Given this list of marker genes Oxct1, Bnip3l, Grn (granulin), Sat1, Zeb2, Adcy7, Ucp2, Lpin1, Abca1, Hbp1, Neurl3, Ccl9, Junb, Aph1c, Apobec1, Adgre4, Lnpep, Prcp (NCBI Gene Id 72461), Igsf6, Fam111a, Il16, Il6ra, Kif21b, Egr1, Stap1, Map4k4, Lst1, Pdcd4 (programmed cell death 4), Crebrf, Cx3cr1, Arhgap9, Lmo4, Cxcr4, Rtn3, Fos, Csk, Plekhm3, Cd180, Kxd1, Hpse, Cerk, Mxd4, Nr4a2, Tsc22d4, Tsc22d3, Foxp1, Alox5ap, Rhob, Parp8, Setx, Txnip (NCBI Gene Id 99524), Il6st, Eif4b, Ctsd (NCBI Gene Id 13033), Ccpg1, Stom (stomatin), Tut4, Ptp4a3, Sgk1 (serum/glucocorticoid regulated kinase 1), Tmem50a, Adgre1, Dnajb14, Fuca1, Lars2 (NCBI Gene Id 245051), Mapk14, Tmcc1, Hspa1a, Smpdl3a, Uba52, Creg1 (cellular repressor of E1A-stimulated genes 1), Bmyc, Ifngr1, Ctsc, Jun, Cox7a2l, Bri3, Nek7, Pik3cg (NCBI Gene Id 76039), Smim14, B4galnt1, Ankrd44 (ankyrin repeat domain 44), Hebp1, Rsrp1, Cd300ld, Ralbp1, Inpp5d, Akap13, Paip2, Nr4a1, Cd300c2, Smc6, Stk38, Il10rb, Anp32a, Stk17b, Timp2 (NCBI Gene Id 52894), Clec2i, Eif3h, Pstpip1, Ctdsp2 (NCBI Gene Id 52468, CTD small phosphatase 2), Gdi2, Ogt, Zfp36l2, Susd3, Rgs10, Cdkn1b, Rgs1, Csnk1g3, Sirpa, Acp5, Ptgs2, Pid1, Klf2, Rab32, Saraf, Ppfia4, Ier2, Deptor, Rnf130, Nav1, Fth1, Plekha1, Cd4, Il13ra1, Slc15a4, Slc12a6, Ccrl2, Mef2c, Bri3bp, Erp29, Polr2e, Borcs6, Fes, Ccl6, H1f2, Il1b, Fam107b, Ramp1, Clec4a1, Gng2, Ptpn18, Ccr2, Leprot, Eef2, Clk1, Pmaip1, Btg2, Ctsh, Haus8, Tnfaip8, Tm6sf1, Clec4a2, Dpy19l1, Ehd4, Smim5, Man2b1, Ttc3, Sox4, Kdm7a, Dusp1, Plxnd1, Cyb5a, Klrd1, Ncf2, Itm2b, Ighm, Arhgap45, Irag2, Rcsd1, Atp2b1, Mbnl2, Npc2, Nfkbiz, Ypel3, Pld4, Tent5a, Neat1, Cybb, Hexa, Ppp1r15a, Septin6, Trappc5 (trafficking protein particle complex 5), Eef1a1, Hspa1b, Fbrsl1, Pold4, Lyz2 (NCBI Gene Id 17107), Kctd12, Celf2, Atp13a2, Zfp36, Glul, Marveld1, Rtraf, Arhgap17, Arhgap15, Add3, Limd2, Klf4, Mdp1, Tnfaip8l2, Niban1, Adipor1, Pfkfb3, Klhl24, Nadk, Eif3e, Gpr141, Iqgap2, Ffar4, Ms4a6b, Shtn1, Ssh2, Prdx6, Atf3, Serinc3, Cd81, Klf6, Mbnl1, Hexb (NCBI Gene Id 15212), Fosb, Amz1, Rgs2, Rbfa, Slc43a2, Emb, Eif3f, Sgpp1, Colgalt1, Nr3c1, Satb1, Tnrc6b, Fbxl20, Hpgd, Abhd12, Tmem234, Arl5c, Rp9, St8sia4, Gpi1, here is a description of the gene set: Cytokines mediate cell-cell communication in the immune system and represent important therapeutic targets. A myriad of studies have highlighted their central role in immune function, yet we lack a global view of the cellular responses of each immune cell type to each cytokine. To address this gap, the authors created the Immune Dictionary, a compendium of single-cell transcriptomic profiles of more than 17 immune cell types in response to each of 86 cytokines (>1,400 cytokine-cell type combinations) in mouse lymph nodes in vivo. A cytokine-centric view of the dictionary revealed that most cytokines induce highly cell-type-specific responses. For example, the inflammatory cytokine interleukin-1β induces distinct gene programmes in almost every cell type. A cell-type-centric view of the dictionary identified more than 66 cytokine-driven cellular polarization states across immune cell types, including previously uncharacterized states such as an interleukin-18-induced polyfunctional natural killer cell state. species: Mus musculus Genes negatively differentially expressed in cell type: cDC2 (conventional dendritic cell type 2) upon treatment with cytokine: IL-2 in mouse lymph nodes in vivo. Mouse Gene Set: CUI_CDC2_IL2_RESPONSE_DN from publication Cui A, Huang T, Li S, Ma A, Pérez JL, Sander C, Keskin DB, Wu CJ, Fraenkel E, Hacohen N (PMID 38057668)